The following is a description of a gene set: part of: Host Interactions of HIV factors Reactome Pathway: Vif-mediated degradation of APOBEC3G The HIV-1 accessory protein Vif (Viral infectivity factor) is required for the efficient infection of primary cell populations (e.g., lymphocytes and macrophages) and 'non-permissive' cell lines. Vif neutralises the host DNA editing enzyme, APOBEC3G, in the producer cell. Indeed, in the absence of a functional Vif, APOBEC3G is selectively incorporated into the budding virions and in the next cycle of infection leads to the deamination of deoxycytidines (dC) within the minus-strand cDNA during reverse transcription.<br>Deamination changes cytidine to uracil and thus results in G to A transitions and stop codons in the provirus. The aberrant cDNAs produced in the infected cell can either be integrated in form of non-functional proviruses or degraded. Vif counteracts the antiviral activity of APOBEC3G by associating directly with it and promoting its polyubiquitination and degradation by the 26S proteasome. <br>Vif binds APOBEC3G and recruits it into an E3 ubiquitin-enzyme complex composed by the cytoplasmic proteins Cullin5, Rbx, ElonginC and ElonginB. Thus, in the presence of Vif, APOBEC3G incorporation into the virion is minimal.<br> species: Homo sapiens, and this is the list of marker genes: UBC, PSMC1, PSMD8, UBA52, UBB, PSMB4, PSMA4, PSMD3, ADRM1, RPS27A, PSMB3, PSMA7, ELOB, PSMD1, CUL5, PSMA1, PSMC5, PSMA5, RBX1, PSMC3, PSMD12, PSMB7, SEM1, PSMD14, PSMA2, ELOC, PSMC2, PSMA3, PSMB1, PSMD11, vif, PSMD6, PSMC6, PSMB5, PSMD13, PSMB6, PSMD7, APOBEC3G, PSMC4, PSMB2, PSMA6, PSMD2